Given this list of marker genes PCDHGB3, GFAP, DNAJB5, NALF2 (NALCN channel auxiliary factor 2), NTSR1, FZD8, SYNGAP1, PCDHGA3, FAM219A, SOX12, DDA1, NME4, LDB3, NAV2 (NCBI Gene Id 89797), RTN4R, PRIMA1, NHERF1, CRHR1, BSN, PODXL, DMWD, CELSR2, GP6, VSTM2L, MEX3A, LHX6, NECTIN1, ATP1B2, C19orf53, SLC8A2, PIERCE1, WIPF2, NOVA2, FBXO46, GORASP1, LHPP, SSBP3, PCDHGA12, TMCC3, RAI1 (NCBI Gene Id 6600), CHST14 (NCBI Gene Id 89881), EGFR, KCNK9, MDGA1, MEOX1, NFIX, ELN, RASL10B, SCN2B, ZNF609, PCDHGA2, CPLX2, RAB25, ONECUT2, IQSEC2, EFNA5, PCDHGA8, SZRD1, WFDC5, CASTOR2, PCDHGA7, RCVRN, SEPTIN9, ZBTB7B, TOM1L2, GPX3, FOXP4, JADE2, AAK1, RGS6, NR4A1, PAX5, KMT2D, KPRP, KIF21B, SRCIN1, SLC7A8, PCDHGB7, NFIC, ARRB1, TFAP4, RHBDL3, PITPNM2, BCAM, SARDH, SIX3, NPTXR (NCBI Gene Id 23467), PCDHGA5, NEUROD6, ZNF584, PTPN14, AIPL1, SGCD, RC3H1, FZD4, FAM107A, YY1AP1, WFIKKN2, POU4F1, NKD1, EPHA8, FAM177B, PATZ1, TWIST2, TBC1D16, CARM1, KLF16, TMEM61, SPTBN4, IQSEC3, CUX1, AK2, KSR2, SNX19, ZBTB7A, PLD3, PCDHGA1, GIT1, PCDHGA11, GRIN2A, ZC3H7B, SPRY4, FGD4, NACC1, RSPRY1, A1CF, ELAVL3 (ELAV like RNA binding protein 3), RIMBP2, VAT1, IGFBP5, PRAF2, SGSM2, MKNK2, CYP2W1, ITPKB, DVL3, ZMYND11, MAB21L2, IGLON5, ASIC1, SLC45A3, TTYH3, PIGL, AQP2, FOXO4, DDN, SOD3, CALB2, GRAMD4, CHRM1, PCDHGC3, FNDC10, SLC48A1, KCNC4, LSMEM2, LMOD1, GNG4, RFX1, PPP1R9B, DAGLA, KCNH1, SH3BP4, HIVEP3, LRRC32, PARVB, CCL21, PIWIL3, SCRT1, RAVER1, CFAP251, ACTR1A, SLC1A7, MSI1, MUC3A, MMP24, RHOF, FCRLA, PCDHGA9, FOXI1, TBX6, EPN1, DNAJC8, ATF7, COX15, PRPS1, PCDHGA10, SSH3, PML, ABCC12, MAP3K13, KLK6, CSRP1, EEF1A1, OLFM2, CDSN, ENTPD2, SNX20, TTBK1, HYOU1, ZNF385A, LIMD2, DLX3 (distal-less homeobox 3), CDKN1A, here is a description of the gene set: Genes predicted to be targets of miRBase v22 microRNA hsa-miR-4651 in miRDB v6.0 with MirTarget v4 prediction scores > 80 (high confidence targets). species: Homo sapiens Human Gene Set: MIR4651 from publication Chen Y, Wang X (PMID 31504780)